The following is a description of a gene set: species: Homo sapiens Human Gene Set: GOBP_REGULATION_OF_SULFUR_METABOLIC_PROCESS Any process that modulates the frequency, rate or extent of the chemical reactions and pathways involving sulfur, the nonmetallic element sulfur or compounds that contain sulfur., and this is the list of marker genes: BCKDK, SLC7A11, TCF7L2, PXYLP1, PDK2, PDK3, NFE2L2, PGK1, PDK4, SNCA, TPK1 (thiamin pyrophosphokinase 1), CTNNB1, SP1, TM9SF2, PDK1, BHMT, MIR21